The following is a description of a gene set: A change in the morphology or behavior of a myeloid cell resulting from exposure to an activating factor such as a cellular or soluble ligand, leading to the initiation or perpetuation of an immune response. Mouse Gene Set: GOBP_MYELOID_CELL_ACTIVATION_INVOLVED_IN_IMMUNE_RESPONSE studied in species Mus musculus, and this is the list of marker genes: Stx4a, Spi1, Adora2b, Cd300a, Ms4a2, Cd177, Ptgds, Dnase1, Fes, Pla2g3, Cx3cr1, Il13, Stxbp1, Kit, Snx4, Stxbp3, Ptpn6, Anxa3, Myd88, Sucnr1, Itgb2l, Dysf, Grn, Stx11, Itgb2, Il13ra2, Cbl, Il33, Havcr2, Cplx2, Dnase1l3, Myo1f, Tyrobp, Lilrb4a, F2rl1, Mrgprb1, Lbp, Kars1, Slamf1, Lat2, Crhr1, Pi4k2a, Sphk2, Nppa, Fcer1a, Nr4a3 (NCBI Gene Id 18124), Fcer1g, Pram1, Mrgprx2, Tnf, Bcr, Vamp2, Il4, Pikfyve (phosphoinositide kinase, FYVE type zinc finger containing), Slc18a2, Il4ra, Prkce, Grp, Enpp3 (ectonucleotide pyrophosphatase/phosphodiesterase 3), Ptgdr, Lypd10, Ccl3, Lat, Btk, Scn11a, Abr, Rabgef1, Gpr15lg, Adora3, Nmi, Ccr2, Unc13d, Sbno2, Ifng, Scnn1b, Itgam, Gab2, Ighe, Ywhaz, Vamp8, Rac2, Milr1, Tac4, Ticam1, Plcg2, Dock2, Ifi35, Rab44, Gata1, Pld2, Syk, Snap23, Pycard, D6Wsu163e, Pdpk1, Hmgb1, Gkn2, Lyn, Chga, Nppc, Cd84, Clnk, Fgr, Trem2, Rasgrp1, Ptafr, Lypd11 (NCBI Gene Id 210155), Fer, Trex1, Stxbp2, Foxf1, Hmox1, Ifnb1, Gata2